Given this list of marker genes Slc29a4, Slc28a1, Arl2, Arl2bp, Slc29a2, Slc29a1, Slc25a4, Slc29a3, Slc25a5, Slc28a3, Slc28a2, here is a description of the gene set: Transport of nucleosides and free purine and pyrimidine bases across the plasma membrane Mouse Gene Set: REACTOME_TRANSPORT_OF_NUCLEOSIDES_AND_FREE_PURINE_AND_PYRIMIDINE_BASES_ACROSS_THE_PLASMA_MEMBRANE studied in species Mus musculus